Given this list of marker genes Actr6, Cfdp1, Ruvbl2, Brd8, Trrap, Ep400, Srcap, Anp32e, Dmap1, Ing3, Kat5, Ruvbl1, Znhit1, here is a description of the gene set: species: Mus musculus A multisubunit protein complex that is involved in chromatin remodeling. It is required for the incorporation of the histone variant H2AZ into chromatin. In S. cerevisiae, the complex contains Swr1p, a Swi2/Snf2-related ATPase, and 12 additional subunits. Mouse Gene Set: GOCC_SWR1_COMPLEX